The following is a description of a gene set: studied in species Homo sapiens Human Gene Set: HP_ABNORMAL_SUBCUTANEOUS_FAT_TISSUE_DISTRIBUTION Abnormal subcutaneous fat tissue distribution, and this is the list of marker genes: AKT1, ATP6V0A2, TBL1XR1, PMM2, ATP6V1A, TGFB1, ATP6V1E1 (NCBI Gene Id 529)